Given this list of marker genes TSSK4, MNS1, RPL10A, CAPN11, EIF5A, CCT5, ATP5PB, TNFRSF18, RPS12, POLR3E, CXCR3, SND1, GEMIN6, WDR74, CDCA7, RPL19, EEF1B2, LEPROTL1, PDLIM2, GNL3, RPL4, ETNK1 (NCBI Gene Id 55500), RPLP0, NSG2, RPL29, RPL37A, LEF1, RPL36, PLEKHA1, EIF3C, ARRB2, PLEKHA2, RPL37, COTL1, EPS8L1, FBL, MAP4K4, ACTN1, DKC1, C1QBP, SPIN2A, EOMES, ZNHIT6, SEPTIN6, PRMT3, TENT5C, SSBP2, TCP1 (NCBI Gene Id 6950), RPL12, RPL36A (ribosomal protein L36a), RPL23, ATP5IF1 (NCBI Gene Id 93974), PLCB2, WWP1, TFRC, MYB, CKS2, YRDC, NCOA3, RPS9, CD3D, HSH2D, WDR43, LAP3, EEF1A1, RPS20, DGUOK, PHF21A, EIF3M, RPL32, RPS10, STAP1, NACA, RNF144A, PSMG1, TBC1D19, RPSA, SMC1A, H4C14, SELL, NOP58, DDX10, PPP1R14B, RPL30, RTP4, TTC4, TAF1D, EHD3, PLAC8 (placenta associated 8), TLR1, PSMB8, MPC2, QTRT1, RBM6, NOP53, RGS10, METTL27, IMPDH2, PSME1, MTHFD1L, RPL39, CTSS, CLTA, TERT, REXO2, CARMIL2, IL6ST, FAM162A, RPLP1, PDE2A, AIMP1, INPP4B, PSME2, DGKA, LTB, BST2, TOMM70, BATF, HOOK1, NEDD4L, RPS27, DPP4, XCL1, ACOT13, RPS3, RPL3, FAU, PRKCB, RPL27, EVL, PDK1, KRT72, RPS26, PRPS1, ADGRG5, TENT5A, RPL24, RUVBL1, PGLYRP1, ERAP1, URB1, TNFSF8, RAD50, GAS5, HSD17B8, CARD10, USE1, FUCA1, PCBP1, DUSP6, RRAS2, FAM78A, PATJ, RPL18, SARAF, THUMPD1, CD27, MAP3K5, LYST, GFM1, BICDL1 (BICD family like cargo adaptor 1), GRAMD2B, FOXK2, IKBKE, ADPGK, TRIM59, RPL23A, RPS2, RALGPS2, H4C16, CD55, CMC1, BTLA, PAICS (phosphoribosylaminoimidazole carboxylase and phosphoribosylaminoimidazolesuccinocarboxamide synthase), SGMS1, here is a description of the gene set: from publication Kress E, Hedges JF, Jutila MA (PMID 16423401) Genes up-regulated in Vd2 gamma delta T cells: untreated versus phorbol myristate acetate and ionomycin. species: Homo sapiens The two major human gd T cell subsets, Vd1 and Vd2, display differences in tissue tropism and agonist responses, but we have little insight into global differences that may exist at the gene expression level. This is due to the small numbers of these cells that can be obtained from healthy donors, which limit comprehensive, comparative gene expression analyses. We established a culture method that expands Vd1 and Vd2 cells from the same PBL preparation to levels sufficient for sorting and microarray analysis. Although the subsets were expanded identically (anti-TCR mAb, plus IL-15), 392 and genes were identified, which were differentially expressed in the two subsets, from two donors, respectively. Approximately genes changed in both subsets following PMA/ionomycin treatment; about 50% of these genes were subset-specific. Both subsets responded to a crude LPS preparation, but only 6% of the responsive genes were the same. The differentially expressed genes were consistent with Vd2 cells being more inflammatory and Vd1 cells having more of a regulatory phenotype. Both subsets expressed transcripts encoding an array of innate and NK cell receptors, supporting the relationship of gd T cells to the innate immune system. Our results show that circulating Vd1 and Vd2 subsets in humans have considerable, inherent differences in gene expression following treatment with non-TCR agonists, supporting unique functional roles for these cells in vivo. Human Gene Set: GSE3720_UNSTIM_VS_PMA_STIM_VD2_GAMMADELTA_TCELL_UP